Given this list of marker genes CCL5, CXCL8, TLR7, IFNG, TLR9, CXCL9, here is a description of the gene set: studied in species Homo sapiens from publication Giarola-Silva S, Coelho-Dos-Reis JGA, Mourão MM, Campi-Azevedo AC, Nakagaki Silva EE, Luiza-Silva M, Martins MA, Silveira-Cassette ACO, Batista MA, Peruhype-Magalhães V, Antonelli LRDV, Leite Ribeiro JG, Elói-Santos SM, Machado AV, Teixeira-Carvalho A, Martins-Filho OA, Araújo MSS (PMID 28549970) Human Gene Set: GIAROLA_SILVA_BLOOD_PANDEMRIX_AGE_21_51YO_30DY_UP Genes up-regulated in blood 30d vs 0d in adults (21-51) after exposure to Pandemrix, time point 30D, administered i.m. The study aimed at identifying biomarkers of immune response elicited by non-adjuvanted-(NAV) and adjuvanted-(AV) H1N1(pdm09) vaccines. The results showed that despite both vaccines elicited similar levels of anti-H1N1 antibodies at day30 after vaccination, higher reactivity was observed in AV at day180. While AV induced early changes in cell-surface molecules on monocytes, CD4<sup>+</sup>, CD8<sup>+</sup> T-cells and B-cells, NAV triggered minor changes, starting later on at day3. Furthermore, AV induced a late and persistent increase in TLR gene expression after day3, except for tlr4, while NAV displayed earlier but transient tlr3/4/7/9 up-regulation. Contrasting with NAV, prominent chemokine gene expression (cxcl8,cxcl9,ccl5) and a broad spectrum up-regulation of plasmatic biomarkers (CXCL8,IL-6,IL-1beta,IL-12,IL-10) was evident in AV, which showed a major involvement of TNF and IL-10. Similarly, AV induced a robust IL-10-modulated proinflammatory storm, with early and persistent involvement of TNF-alpha/IL-12/IFN-gamma axis derived from NK-cells, CD4<sup>+</sup> and CD8<sup>+</sup> T-cells along with promiscuous production of IL-4/IL-5/IL-13. Conversely, NAV promotes a concise and restricted intracytoplasmic chemokine/cytokine response, essentially mediated by TNF-alpha and IL-4, with late IL-10 production by CD8<sup>+</sup> T-cells. Systems biology approach underscored that AV guided the formation of an imbricate network characterized by a progressive increase in the number of neighborhood connections amongst innate and adaptive immunity. In AV, the early cross-talk between innate and adaptive immunity, followed by the triad NK/CD4<sup>+</sup>/CD8<sup>+</sup> T-cells at day3, sponsored a later/robust biomarker network. These findings indicate the relevance of adjuvanted vaccination to orchestrate broad, balanced and multifactorial cellular immune events that lead ultimately to a stronger H1N1 humoral immunity.